Given this list of marker genes FLRT1, SORCS2, AP5B1, WDTC1, TTYH3, SLC8A3, TMEM239, ABLIM3, CSF1, SPNS2, DENND4B, CHAC1, CHGA, LRRC20, TBC1D22A, USP2, HEMK1, HAPLN4, NEURL1, MTCL2, DGKD, PLEKHA6, SPOCK2, SEZ6, ISM2, DEDD2, ASB8, RXRG, VRK3, NDUFA2, PPARGC1A, VPS37D, INTS6, NPLOC4 (NCBI Gene Id 55666), TRARG1, FAM53A, SERF2, PPP3CB, ORAI2, DEXI, FKBP5, ZNF704, VPS39, MEGF11, USP42, TMEM120B, TMEM185A, PITPNM3, NOTCH2 (notch receptor 2), SNTB2, SPICE1, NHLRC3, RNF135, DAB2IP, ZER1 (NCBI Gene Id 10444), OTUD7A, VDR, TBC1D13, ABAT, DDB1, KCNJ10, RAPGEF5, SUSD5, B3GNT7 (UDP-GlcNAc:betaGal beta-1,3-N-acetylglucosaminyltransferase 7), RAB5B, THNSL2, CYTH1, TMOD2, ADAMTS6, SEZ6L2, PTPN12, GRB10, ACTR1A, EEIG1, SLC43A2, NTN1, ATP2B1, CPEB3, NALF2, MS4A7, GIMAP1, WNT9B, REPIN1, GPM6A, APH1A, TNS3, SLC23A3, SLC6A17, CCNY, SLC35B1, NAGS, NDOR1, GAS7, ZNF512B, OLFML2A, KLHDC8A, PSMA3, PNMA8B, PHF8, SDR16C5, BIK, ERF, CADM3, NATD1, TRIM7, MVB12B, BMF, UACA, PSMD9, RPL13, SLMAP, RPL13A, RPL41, GSTZ1, SYT9, PACS2, CISH, CST9, PPP2R5D, MICOS10, POU2F2, here is a description of the gene set: from publication Chen Y, Wang X (PMID 31504780) Genes predicted to be targets of miRBase v22 microRNA hsa-miR-4685-5p in miRDB v6.0 with MirTarget v4 prediction scores > 80 (high confidence targets). studied in species Homo sapiens Human Gene Set: MIR4685_5P